The following is a description of a gene set: from publication Lindvall JM, Blomberg KE, Berglöf A, Yang Q, Smith CI, Islam TC (PMID 15214046) Genes down-regulated in comparison of primary splenic B cells from wild type mice versus those from Xid mice. Bruton's tyrosine kinase (Btk) is important for B lymphocyte development. To identify genes that are differentially expressed in primary B cells lacking functional Btk, splenocytes from X-linked immunodeficiency (Xid), Btk knockout (KO) and immunocompetent CBA mice, were used in microarrays containing more than genes and expressed sequence tags (ESTs). We found 4515 transcripts expressed in duplicate experiments in all three strains. Out of these, 38 were differentially expressed genes (21 up-regulated >2 fold and 17 down-regulated <-2 fold) between CBA and Btk defective mice. Ten out of these genes were selected and quantitative Real-Time PCR was conducted for validation and further investigation. Real-Time experiments correlated nicely with the microarray data. No definitive phenotypic difference has previously been reported between Xid and Btk KO mice. We found genes, whose expression differed (>2 fold) between the two strains. Moreover, when the genes, which differed between immunocompetent CBA and Btk defective mice were ranked according to fold-increase, the levels in Btk KO mice were significantly more altered. This suggests that the defect in Btk KO mice is more severe and demonstrates that the mutant Btk protein in Xid mice does not generally function as dominant negative form. studied in species Homo sapiens Human Gene Set: GSE2826_WT_VS_XID_BCELL_DN, and this is the list of marker genes: COL19A1, PDGFA, SERPINA5, VCAM1, GRPEL2, CELF4, SCN7A, CMBL, PTCH1, GNG10, UBL3, ADCY9, AGAP3, CDKN2D, GATM (NCBI Gene Id 65211), ADA, P4HA2, NRL, XIAP, ECE1, CALML5, SOX4, KRT2, HMGB3, COL1A2, INSIG1 (NCBI Gene Id 3638), MAP2K1, PROX1, TRAPPC2L, NXN, CCL2, BEX4, ATP1B1, GTF3C4, PTGES, SERPINB6, SOCS2, SLC30A1, STX7, VAPB, PALD1, RPIA, TULP1, CFHR2 (complement factor H related 2), ENTPD7, MAPKAPK2, FBLN2, FCRLA, AKR1A1, SLC15A2, FHOD3, GATA1, BRD7, LAMP2, UBE2C, FGF14, APP, SMPD2, AXL, F12, SLC2A5, ITM2B, IFT88, SUMO3, GNA15, RXYLT1, PLA2G7, CPQ, DOCK5, MYL3, AARD, AQP8, GC, RECK, UPK3B, CHMP4B, PTPRO, CMC2, CBX7, PLA2G2C, SBF2, SPP1, RNF138, NAV1 (neuron navigator 1), IFNGR1, LARGE1, PIP4K2A, MESD, GALNT3, KDM5B, LGALS4, SLC25A10, F9, ST3GAL5, TMEM230, ASTN1, CTSA, ZNF703, GLIPR2, PTGIS, CASP14, RYR3, POLG2, TM2D2, MYH1, LDB3 (LIM domain binding 3), CYP17A1, LXN, TGFBI, TRAF2, HOXD11, STX2, ABCG2, ADAMDEC1, SLC12A2, CPNE3, TIE1, TSHR, EMCN, PGM2, PPT2, EPAS1, CDK18, GPC4, JTB, FTL, ITGB5, VPS4A, CPD, KCNS2, KRT81, NR6A1, USP39, PPP5C, CD47, INTS7, IGFBP6, TLE3, TSPAN4, SPINT1, CD48, SGCG, SEMA5A, LRPPRC, CYP21A1P, CELA1, PISD, GLO1 (NCBI Gene Id 2739), SIX2, SPIC, NFKB2, CADM1, JMJD8, TMEM37, ESR1, NHERF1, SLC1A5, PRSS58, FAM151A, RAC1, MAP3K6, AIF1, CRYAB, PPP1R3C, ELOVL6, FAAP20, CPLX2, HEBP1, BAIAP2L1, ITFG1, AATK, HTR4, VWF, PLEKHA5 (pleckstrin homology domain containing A5), GABRA2, DBNDD2, ADCY6, COL2A1, ADAM8 (ADAM metallopeptidase domain 8), DDRGK1, RAB33B, LY6D, IRF6, DSTN, HOXD3, OAZ2, EMC6, CISH, GLCE, RNF38, EDA, VPS26A, PTPRK, PLXNB2, PSAP, ACP5, CLCN5, ALDH9A1, SNTA1 (syntrophin alpha 1), CD300C